Given this list of marker genes CDC25C, TFDP1, ZNF385A, PRMT1, EP300, CARM1, TFDP2, SFN, RBL2, GADD45A, BAX, CCNB1, E2F4, TP53, RBL1, CDK1, AURKA, PCNA, here is a description of the gene set: TP53 contributes to the establishment of G2 arrest by inducing transcription of GADD45A and SFN, and by inhibiting transcription of CDC25C. TP53 induces GADD45A transcription in cooperation with chromatin modifying enzymes EP300, PRMT1 and CARM1. GADD45A binds Aurora kinase A (AURKA), inhibiting its catalytic activity and preventing AURKA-mediated G2/M transition. GADD45A also forms a complex with PCNA. PCNA is involved in both normal and repair DNA synthesis. The effect of GADD45 interaction with PCNA, if any, on S phase progression, G2 arrest and DNA repair is not known. SFN (14-3-3-sigma) is induced by TP53 and contributes to G2 arrest by binding to the complex of CDK1 and CCNB1 (cyclin B1) and preventing its translocation to the nucleus. Phosphorylation of a number of nuclear proteins by the complex of CDK1 and CCNB1 is needed for G2/M transition. While promoting G2 arrest, SFN can simultaneously inhibit apoptosis by binding to BAX and preventing its translocation to mitochondria, a step involved in cytochrome C release. TP53 binds the promoter of the CDC25C gene in cooperation with the transcriptional repressor E2F4 and represses CDC25C transcription, thus maintaining G2 arrest (St Clair et al. 2004, Benson et al. 2014). The zinc finger transcription factor ZNF385A (HZF) is a direct transcriptional target of TP53 that can form a complex with TP53 and facilitate TP53-mediated induction of SFN transcription. species: Homo sapiens part of: TP53 Regulates Transcription of Cell Cycle Genes Reactome Pathway: TP53 Regulates Transcription of Genes Involved in G2 Cell Cycle Arrest